Given this list of marker genes Atat1, Ntrk3, Socs3, Nfkb1, Lamp2 (lysosomal-associated membrane protein 2), Fcgr2b, Zdhhc1, Itch, Vhl, Tril, Was, Fndc4, Traf6, Lrp8, Apoe, Adtrp, Tmem161a, Ifnlr1, Enpp4, Kdm4d, Ccr2, Gpsm3, Polq, Il1rl1, Cry1, Plcg2, Mvk, Fxr1, Bmp10, Casp1, Ppard, Ifi209, Hic1, Ifi204, Kat5, Brca1, Trp73, Siglece, Tarbp2, Helb, Atr, Tnfrsf1b, Il17rb, Slc7a11, Ubqln2, Bcap31, Tyrobp, F11, Clpb, Lgals1, Nlrp4c, Tmprss6, Znhit1, Adra2a, Nlrp5 (NCBI Gene Id 23968), Tnfrsf12a (NCBI Gene Id 98086), Ppia, Ifi203-ps, Unc13b, Ppp4c (protein phosphatase 4, catalytic subunit), Daglb, Fmn2, Gm15441, Pik3cg, Eya1, Mcph1, Serping1, Tbxa2r, Ptger4, Akna, Gper1, A2m, Lrig2, Tlr11, Fkbp1b, Tnip1, Kmt5a, Rbx1-ps, Sec14l1, Eif2ak3, Ifi203, Clec7a, Aurkb, Irak3, Atm, Tnfsf11, Mmp8, Drosha, Prkd1, Lta (lymphotoxin A), Cd200l1, Trem2 (triggering receptor expressed on myeloid cells 2), Rbx1 (NCBI Gene Id 80401), Smarca4, Dpp4, Sh2d1a, Trim62, Serpinb9, Clasp1, Yy1, Lyar, Elmod2, Susd4, Serpinb9e (serine (or cysteine) peptidase inhibitor, clade B, member 9e), Grpr, Mylk, Mapk8, Dnajb9, Nek7, Flna, Eppk1, Il12a, Dnmt3a, Senp3, Mettl3, Kank1, Emilin1, S100a8, Taok2, Klrb1, Brca2, Ikbkg, Alpk1, Map3k7, Uchl5, Pias4, Mmrn2, Nfe2l2, Drd2, Cd200l2, Nkg7, Cactin, Bcl7a, Trim5, Cx3cl1, Rnf26, Csnk2a1, Map2k1, Ppp1r13l, Terf2ip, Socs5, Tlr8, Pdcd4, Rnf146, Grem1, Pdpk1, Foxa2, Oxr1, Btk, Serpinb9d, Cdk9, N4bp1, Ggt1, Nlrp9a, Usp38, Mavs, Klrb1b, Park7, Pttg1ip (NCBI Gene Id 97646), Clec4e, Taf12, Pdgfa, Fbh1, Cd200r4, Usp27x, Insig1, Tnfaip8l2, Gpr108, Zfp385a, Il16, Crk, Tbc1d24, Ucn, Slc39a8, Morf4l2, S100a14, Gp1ba, Fut8, Nop53, Adora3, Smarce1, Oprm1, Ahsg, Arl6ip5, Ddah1, Mgmt, Cdkn2d, Plaur, Tspan32, Eny2, Fbln5, Usp15, Arid2, Il23a, Rnf170, Lamp1, Trim3, Ncf1, Zdhhc9, Tgfb1, Dnaja3, Usp50, Atad5, Nfe2l1, Klhdc10 (NCBI Gene Id 76788), Pvr, Ripk2, Nectin2, Ajap1 (adherens junction associated protein 1), Pnpla8, Klrb1c, Ing3, Atxn7l3, Gps2, Gimap5, Slf2, Stub1, Cpt1a, Ifna1, Serpinf2, Myoz1, Abhd12, Rtel1, Srebf1, Ppp4r3c2, Mctp1, Tnr (tenascin R), Mif, Ercc4, Gbp2, Ywhae, Syvn1 (NCBI Gene Id 98160), Mlip, Abcd1, Ggt7, Oas1g, Psg23, Bpifb1, Traf3ip2, Riok3, Calhm2, Dusp10, Eif2ak1, Ticam2, Nmi, Tmem97, Il2ra, Adcyap1r1, Actr2, Xrcc1, C2cd4b, Actr8, Taok3, Oas1h, Ppl (periplakin), Isl1, Vav1, Txk, Mdm2, Wrap53, Tlr5 (toll-like receptor 5), Irak1, Errfi1, Cyren, Taf9, Ccn3, Uimc1, Oas1b (NCBI Gene Id 23961), Nt5e, Ulbp1, D1Pas1, Cd300c, Usp51, Fem1al (fem-1 homolog A like), Top2b, Ifi213, Klrb1f, Acp5 (NCBI Gene Id 11433), Tifa, Nr1d1, Cebpg, Hdac10, Diaph2, Cfh, Pdx1, Casp6, Nod2, Ddr2, Sh2d1b1, Ano6, Smarcc1, Zp3, Fpr2, Psma1, Cadm1, Usp14, Adam17, Ptprf, Appl2, Washc4, Banf1, Igfbp6, Slf1, Lrp1, Ffar4, Fpr-rs6, Gp5, Alox15, Kat7 (K(lysine) acetyltransferase 7), Il22ra2, C3, Sirt7, Abhd17a, Fech, Epha4, Agr2, Igf2, Polr3g, Apoh, Rag1, Gkn2, Pla2g10, Fads2, Ahr, Lyn, Trim12c, Abl1, Bcl6, Tigar, Sertad3, Smarcd1, Srsf6, Il21, Klri2, Grn, Clec2d, Rftn1, Pla2g5, Fabp4, Bcr, Serpinb9f, D130043K22Rik, Cln3, Vkorc1, Tada3, Ercc6, Il10, Parp3, Klf4, Hspa8, Znrf4, Hpx, Psmd10, Prdx2, Polr3c, Cd109, Pten, Ccr7, Rnf185, Il6, Acod1, Usp25, Fanca (Fanconi anemia, complementation group A), Pmaip1, Met (met proto-oncogene), Bid, Lgals2, Hbegf, Timeless, Alox5ap, Aoah, Pbrm1, Gramd4, Hsf1, Cd28, Apbb1, Nol3, Cck, Cyld, Nod1, Rnf126, Pnkp, Ifi211, Map3k8, Crh, Usp47, Phf13 (NCBI Gene Id 230936), Sema7a, Cdkn2a, Zdhhc3, Ptpn6, Mre11a, Ldlr, Prkce (NCBI Gene Id 98094), Bok, Arf6, Gpatch3, Rtn4, Hrg, Ankrd1, Ino80b, Cd81, Tifab, Lrch4, Spring1, Foxc2, Setd4, Ppp6c, Atp2b4, Pde5a, Ccr5, Hyal2, Hapstr1, Trim56, Otop1, Plk1 (polo like kinase 1), Vtn (vitronectin), Parg, Inpp5d, Nlrp1b, Serpine1, Dyrk3, Spire1, Ninj1, Oas1a, Ruvbl2, Brd8, Tpsab1, Hmgcr, Pgc, Bcl7b, Chrna7, Itgb1, Taf6l, Irf1, Cldn13, Qars1, Rfwd3, Smarcd3, Shld3 (NCBI Gene Id 113002583), Adcyap1, Mfhas1, Ifi207, Rps6ka3, Arg1, Muc19, Ing4, Il15, Dnase1l3, Mas1, Hamp, Ly96, Trim65, Spidr, Appl1, Rictor (NCBI Gene Id 78757), Cep63, Spata2, Mapt, Snai1, Ier3, Myo1f, Cnot7, Tlr4, Pla2r1, Cst7 (NCBI Gene Id 13011), Sh2d1b2, Selenos, Taf5l (NCBI Gene Id 71789), Pum1, Cd160, Ptges, Braf, Klrc1, Npy, Ifi35, Fam3a, Ndfip1, Bst1, Crebbp, Nlrp12, Duox1, Micu1, Usp13, Usp29, Ryr1, Foxo1, Rps19, Erbin, Gbp4, Cd44, Atf6, Polr3b, Fpr-rs7, Prkcg (protein kinase C, gamma), Fga, Spop, Insig2, Erp29, Mcrs1, Irf2, Tnfrsf11a, Eya4, Actb, Klk7, Ecsit, Steap3 (NCBI Gene Id 68428), Fancd2, Spsb3, Sirt6, Tap1, Eif4e2, Cd200r3, Kremen1, Rigi, Phb1, Ogt, Irf3, Nr1h3, Rela, Hdgfl2, Slc15a2, Penk, Oas1e, Fut7, Ccl2, Coro2b, Bax, Rnf169, Apobec3, Mgll, Mad2l2, Fcgr3, Fem1b, Bap1, Naglu, Sf3b3, Rnf144a, Nck1, Nlrp4a, Cxcl17, Bcl7c, Cma1, Fermt2, Creb3l1, Ltf, Yeats4, Htr2a, Nbr1, P2rx7, Fgr, Ndel1, Hbb-bs, Sirt2, Khdc3 (KH domain containing 3, subcortical maternal complex member), Casp12, Mrgbp, Hspb1, Klrc2, Muc1, Rnf168, Klri1, Smyd2, Ipo5, Klrk1, Pink1, Ptgis, Rpa2, Sgta, Il17f, Ddias, Stk24, Sgf29, Mapkap1, Rbm14, Serpinb9g, Hif1a, Pde2a, Zc3hav1, Supt7l, Zc3h12a, Serpinb9b, Gch1, Grp, Tnip3, Cul4a, Commd1, Napepld, Nfkbiz (NCBI Gene Id 80859), Esr1 (estrogen receptor 1 (alpha)), Dpf2, Mdk, Nr5a2, Xylt1, Fus, Nlrc5, Babam1, Tlr12, Cgas, Tmsb4x, Eif2ak2, Nlrp9c, Tslp, Stat2, Shld2 (shieldin complex subunit 2), Pparg, Ptpn22, Trafd1, Cd9, Jak2, Fignl1, H2-T23, Cd300lf, Smim30, Rab11fip2, Znrf1, Prkca (NCBI Gene Id 18750), Rb1, Lgr4, Foxm1, Dagla, Aoc3 (NCBI Gene Id 11754), Clasp2, Irgm1, Tsc1, Zdhhc4, Rnf125, Trim44, Ager, Eno1b, Twist1, Ruvbl1 (NCBI Gene Id 66484), Mapk8ip2, Dmap1, Fpr-rs3, Svip, Clnk, Tspan6, Abca7 (ATP-binding cassette, sub-family A member 7), Ptgs2, Dcst1, Cd24a, Mapkbp1 (mitogen-activated protein kinase binding protein 1), Cldn1, Adamts18, Ccl1, Tap2, Aars2, Mmp14, Tnfsf4, Axin2, Yju2, Ptk2, Sarm1, Skp2, Trim41, Irgm2 (immunity-related GTPase family M member 2), Raet1d, Ptpn1, Oas1d, Cpb2, Egfr, Tnip2, Il22b, Smad3, F12, Rnf216, Slc15a3, Dmtn, Ufd1, Nr1h5, Tbc1d23, Nlrp4b, Insl3, Tex15 (NCBI Gene Id 73664), Ccdc134, Pcbp4, Crtam, Zbtb7b, Spi1, Zmpste24, Tmem33, Gimap3, Hdac6, Smarcd2, Irak2, Ppp4r2, Foxf1, Setd6, Suv39h1, Igf1r, Nono, Crhbp (NCBI Gene Id 12919), Ins1, Ppp4r3b, Pdgfb, Otud4, Ccl24, Havcr2, Cx3cr1, Hmgb2, Radx, Nr1d2, Slc12a2, Il23r, Ednrb, Epc1, Fgf10 (fibroblast growth factor 10), Rad9a, Xiap, Ifi206, Lpl, Git1, Cd200, Rad51, Skil, Tafa5, Raet1e, Alox5, Grina, Lep, Smpdl3b, Osm, Slc46a2, Ogg1, Atxn7, Reg3a, Pcna, Dab2ip (disabled 2 interacting protein), Trpv4, Brcc3dc, Inava, Mir147 (microRNA 147), Mtor, Stat5b, Pglyrp2 (NCBI Gene Id 623596), Trp53, Nlrx1, Taf7, Trex1, Kars1, Ighg1, Ybx3, Ajuba, Ifi214, Cldn4, Cd200r2, Usp17le, Ube2v2, F7, Ubqln1, Samhd1, Cyp19a1, Stk39, Dhx9, Fbxl2, Kdm6a, Cntf (NCBI Gene Id 12803), Cops3, Kng1, Chuk, Ghsr (NCBI Gene Id 208188), Knl1, Prdx1, Rpl26, Inpp5f, Ash1l, Ooep, Atf6b, Brd4, Csnk1a1, Rgma, Setd7, Duoxa2, Recql5, Meak7, Mmp12, Casp8, Sharpin, Ythdf2, Wnt5a, Gpr4, Rnaseh2b, Eif2a, Il10ra, Unc93b1 (unc-93 homolog B1, TLR signaling regulator), Rmi2, Map3k20, Serpinb1a, Vamp8, Cdh5, Smarcc2, Lgals9, Cd37, Cxcl1, Il33, Ptgs2os, Il12b, Arfgef1, Trim6, Bcl6b, Becn1, Nlrp10, Ap3b1, Fgf2, Hsp90aa1, Trim30c, Tax1bp1, Fas, Gdi1, Abcb1b, Ppp3ca, Mul1, Drd1, Ptger3, Ube2n, Brcc3, Neo1, C1qtnf12, Zdhhc18, Manf, Rnf26rt, Il1a, Parpbp, Ddt, Fpr-rs4, Ywhaz, Lrrc14, Ttll12, Trim30b, Lpcat3, Il1b, Blm, Rora, Klkb1, Lrsam1, Mlc1, Kcnk2, Dnase1, Taf6 (NCBI Gene Id 21343), Fgg, Celf1, Zfp36, Cldn19, Nt5c2, Phldb2, Rnf115, Gja1, Cav1, Nlrp4f, Tnfsf18, Mrnip, Ell3, Fgb, Gypa, Lmna, Slc19a1, Fgl2, Stk25, Ercc8, Ifi205, Grb2, Ap1g1, Tac1, Nsd2, Rnft1, Cdc37, Trim15, Il27, Ido1, Taok1, Sod1, Cptp (NCBI Gene Id 79554), Nlrp1a, Nudt16l1, Stat1, Il2, Fosl1, C1qbp, Usp22, Thbs1, Optn, Oas3, Dpf3, Acacb, Cd96, Sirt1, Txndc12, Mapkapk2, Muc16, Abcb1a, Hcfc2, Pdcd10, Trim12a, Psmb4, Arg2, Serpinb9h, Bard1, Snca, Peli1, Tfpi, Il12rb1, Eya3, Nlrc4, Lats2, Ephb2, Pqbp1, Kat2b, Serinc3, Rock2, Rnf135, Ubxn2a, Klrb1a, Crebrf, Il22ra1, Tgfb2, Fam168a, Ino80, Trim28, Nfrkb, Pcbp2, Ubxn1, Paqr3, Igtp, Tafa3, Calhm6, Ifnb1, Pml, Taf2, Rnft2, Sbno2 (strawberry notch 2), Foxp3, Atg12, Ern1, Wdfy1, Rab34, Thbd, Zbp1, Stk19, Vps35, Sesn1, Vps72, Snai2, Nploc4, Cd276, Zfp365, Lyplal1, Smpdl3a, Gsdmd, Akt3, Bad, Prmt1, Pspc1, Cebpb, Hpse, Extl3, Prrx1, Treml4, Nppa, Agt, Lrrfip2, Ino80c, Rasgrp1, Vsig4, Ctsc, Bag6, Tmbim6, Casp4, Stox1, Bak1, Spred2, Pot1b, Xbp1, Kdm1a, Ifi208, Sh2b3, F2rl1, Ddx60, Ilrun, Trrap, Atp7a, Rasgrp4, Atad3a (NCBI Gene Id 71964), Eya2, Ercc1, Rif1 (replication timing regulatory factor 1), Elp6, Kcnk13, Fem1a, Prkar1b, Xrcc4, Pigbos1, Ivl, Metrnl, Cd300ld3, Card9, Syk, Rabgef1 (RAB guanine nucleotide exchange factor (GEF) 1), Abr, Otub1, Mbtd1, Cldn3 (claudin 3), Mefv, Opa1, Cops5, Cxcr4, Colec12, Pros1, Lsm14a, Tbk1, Cd36, Trp53bp1, Rad51ap1, Wfs1, Brd7, Tlr1, Adora1, Il18 (NCBI Gene Id 16173), Dicer1, Clec12a, Babam2, Kmt5b, Slc25a23, Helq, Tkfc, Ddx11, Oasl1, Ythdf3, Fermt1, Rbm47, Cbx8, Arel1, Morf4l1, Adora2b, Diaph1, Arrb2, Nacc2, H2-M3, Sbno1, Ikbke, Nrg1, Dnaja1, Lbp, Aifm2 (NCBI Gene Id 78860), Cd300a, Eno1, Traf3ip3 (NCBI Gene Id 98261), Hspa5, Tspan8, Ubash3b, Atxn3, Trim25, Pdia6, Tti1, Rps3, Nbn, Wfdc1, Ripk1, Nlrp14, Cers2, Parp1, Mill1, Tfpt, Tradd, Csf1r, Ankrd17, Smarcb1, Sfpq, Hgf, Crhr2, Supt20, Wdr48, Ets1, Adamts12, Ticam1, Reg3g, Gpx1, Hexim1, Gata3 (GATA binding protein 3), Bdkrb2 (NCBI Gene Id 12062), Prkg1, Fcna, Ccl5, Stat3, Armh4, Thy1, Tlr7, Ier5, Cd274, Atg5, Ccar2, Gata6, Prkcd, Anxa5, Hras, Nlrp9b, Dhx33, Setd2, Dtx4, Slamf6, Tmed2, Efhd1, Rtn4r, Dek, Lilra5, Mir7578, Ppp4r3a, Tff2, Klhl15, Rreb1 (ras responsive element binding protein 1), Ffar3, Hmgb1, Rnf31, Tldc2, Trem3, Scly, Gfi1, Shank3, Kcnn4, Trim45, Mapk3, Adora2a, Daxx, Klk5, Hnrnpk, Selenon, Rnf183, Ppp1r10, Letmd1, Nr1h2, Tlr2, Ncr3-ps (NCBI Gene Id 674165), Dsg2, Bcl2l12, Actl6a, Pik3ap1, F2r, Igf1, Oas1f, Traf3, Ncoa7, Il1r1, Stmp1, Gbp2b, Npy5r, Rab7b, Ereg, Pbk, Sphk1, Polr3f, Actg1, Tlr6, Gbp3, Il17a, Pmp22, Plat, Rtn4rl1, Aqp11, Gpr31b, Adam8, Plau, Gigyf2, Lrrc19, Actr5, Tnf, Sf3b5, Marchf7, Keap1, Ighg2b, Mark4, Med1, Vegfb, Myd88, Plg, Nr1h4, Pot1a, Anxa2, Rnf34, Sema4c, Tmx1, Vil1, Lats1, Fcgr1, Ccl3, Ppt1, Meaf6, Matr3, Mtch2, Rad52, Plscr1, Letm1, Hyou1, Uaca, Foxp1, S100a9, Sesn3, Znfx1 (NCBI Gene Id 98999), Pja2, Ifih1, Alox12, Phb2, Tab1, Nectin4, Chek1, Arnt (aryl hydrocarbon receptor nuclear translocator), Pla2g2d, Sqstm1, Pum2, Tlr9, Fcer1g, Kat2a, Pim1, Riox1, Ddx3x, Cxcl5, Ep300, Isg15, Ffar2, Nlrp6, Trim11, C2cd4a, Slc38a2, Mndal, Tlr13, Ackr3, Bcl10, Rhbdd3, Tmem259, Sin3a (NCBI Gene Id 20466), Tpt1, Sncg, Klrc3, Scarf1, Bcl2l1, Sucnr1, Anxa1, Trim31, Setmar, Tmem67 (transmembrane protein 67), Fbxo4, Adcy8, St3gal4, Fcer1a, Herpud1, Epc2, Cd300e, Pla2g3, Epor, Snx4, Il13, Cd74, Il17ra, Macir (NCBI Gene Id 98651), Fam76b, Ube2k, Taf10, Irf4, Enpp3, Slc7a2, Krt1, Ep400, Zcwpw1, Nlrp4e, Cadm4, Il18rap, Creb3, Cd86, Pik3cb, Camk2n1, Spred1, Tnc, Clcf1, Zdhhc11, Src, Pglyrp1, Apoa1, Smchd1 (SMC hinge domain containing 1), Htra1, Abcc1, Npas2, Tnfaip3, Gstp1, Spn, Lrfn5, Hspa4, Nagk, Ino80d, Otulin, Ctss, Ccn4, Atrip, Ppara, Zdhhc12, Usp19, Ppp2ca (protein phosphatase 2 (formerly 2A), catalytic subunit, alpha isoform), Arid1a (AT-rich interaction domain 1A), Omg, Il22, Cfhr4, Serpinc1, Gbp5, Chchd2-ps, Aim2, Npm1, Fcnb, Ddx5, Adipoq, Xrcc6, Traf3ip1, Gm12250, Kmt5c, C1qtnf1, Lrrk2, Pycard, Gpr17, Epo, Dtx3l, Trim32, Mapk1 (NCBI Gene Id 98012), Sfn, Ccr1, Clec4n, Epg5, Casp3, Wdr76, Ccdc117, Rtca, Sesn2 (sestrin 2), Zdhhc5, Adar, Tasl, Pf4, Clock, Ceacam1, Trpc3 (transient receptor potential cation channel, subfamily C, member 3), Fancb, C1qtnf3, Selenok, Slc15a4, Kcnj8, Etaa1, Gpx2, Parp9, Tada1, Ppp4r3c1, Chordc1, Nlrp2, Ppm1b, Prkn, Slamf8, Tlr3, Pomc, Klre1, Trpm2, Ddrgk1, Stat5a, Klrd1, Akt1, Tyro3, Amfr, Usp18, Smoc2, Eef1e1, Usp1, Sox4, Evpl, Slc25a14, Clec12b, Il20rb, Trim30d, Ins2, Cd300c2, Shpk, Eif2ak4, Vwf, Aunip, Nupr1, Tnfaip6, Elf4, Dyrk1a, Ifng, Smarca2, Cask, Cd47, Pnp, Bfar, Nek1, Irf7, Reg3b, Cd14, Pik3r6, Tomm70a, Map4k4, Triap1, Phf10, Flot1, Abraxas1, Mmrn1, Ficd, Ctla2a (NCBI Gene Id 13024), Duox2, Tirap (NCBI Gene Id 117149), Duoxa1, Ttbk1 (NCBI Gene Id 106763), Ghrl, Tnfrsf1a, Cebpa, Fh1, Mkrn2, Prkdc, Scimp, Nck2, Trim21, Cd200r1, Actl6b, Hspd1, Macroh2a1, Map2k2, Parp14 (poly (ADP-ribose) polymerase family, member 14), Wnt4, Ufl1, Pdgfra, Polr3d (NCBI Gene Id 67065), Xcl1, Nlrp3, Pik3r1, Lacc1, Clu, Sting1, Dhfr, Cxcl12, Fadd, Cd226, F2 (NCBI Gene Id 14061), Nfkbia, Cnr1, Il4, Siglecg, Kng2, Mid1, Taf5, Cyba, Ada (adenosine deaminase), Mef2c, Rnf8, Sirpa, Proc, Dpf1, Gprc5b, Shld1, Mapkapk3 (mitogen-activated protein kinase-activated protein kinase 3), Emilin2, Mbtps2, Lag3, Trim38, Gfer, Dhx58, Peli3, Oas1c, Scgb1a1, Hmga2, Xrcc5, Stap1, Ptpn2, Hspa1b, Nfkbil1, Ppp2r3c, Akirin2, Cckbr, Akt2, Gbp7, Syt11, Mbl2, Il1rl2 (interleukin 1 receptor-like 2), Tmem126a, Serpine2, Nlrc3, Serpinb9c, Rsad2, Zcchc3, Ptprs, App, Spire2, Ubqln4, Ptn, Trim30a, Ddx39a, Chchd2, Chek2, here is a description of the gene set: Any process that modulates the frequency, rate or extent of a response to stress. Response to stress is a change in state or activity of a cell or an organism (in terms of movement, secretion, enzyme production, gene expression, etc.) as a result of a disturbance in organismal or cellular homeostasis, usually, but not necessarily, exogenous (e.g. temperature, humidity, ionizing radiation). species: Mus musculus Mouse Gene Set: GOBP_REGULATION_OF_RESPONSE_TO_STRESS